The following is a description of a gene set: species: Homo sapiens from publication La Manno G, Gyllborg D, Codeluppi S, Nishimura K, Salto C, Zeisel A, Borm LE, Stott SRW, Toledo EM, Villaescusa JC, Lönnerberg P, Ryge J, Barker RA, Arenas E, Linnarsson S (PMID 27716510) Human Gene Set: MANNO_MIDBRAIN_NEUROTYPES_HRGL3 Cell types are named using anatomical and functional mnemonics prefixed by 'm' or'h' to indicate mouse and human respectively: OMTN, oculomotor and trochlear nucleus; Sert, serotonergic; NbM, medial neuroblast; NbDA, neuroblast dopaminergic; DA0-2, dopaminergic neurons; RN, red nucleus; Gaba1-2, GABAergic neurons; mNbL1-2, lateral neuroblasts; NbML1-5, mediolateral neuroblasts; NProg, neuronal progenitor; Prog, progenitor medial floorplate (FPM), lateral floorplate (FPL), midline (M), basal plate (BP); Rgl1-3, radial glia-like cells; Mgl, microglia; Endo, endothelial cells; Peric, pericytes; Epend, ependymal; OPC, oligodendrocyte precursor cells., and this is the list of marker genes: FLJ16779, KCNMA1, CRB1, TIMP4, MRPL57, FADS2, LRRC17, SIPA1L2, QKI, RHOJ, CMTM4, PAM, ADGRV1, SPON1, CFAP44, SUSD5, TPPP3, PPP1R14C, MAP3K5, ZNF474, SULF2, PSAT1, COBL, MTTP, DNAH6, CPNE8, THSD7A, C6orf89, PLEKHH2, FREM2, EFCC1, TNIK, IFT88, NES, PDE1C, SULF1, PLEKHA5, FAT1, CRISPLD1, DENND2B, SLIT1, HBG2, UCP2, VWA3A, DLG5-AS1, GRIN2A, SCD, SERTM1, ZMAT4, RSPH9, SCN1A, GCA, DTNA, ID4, ITGA6, DCDC2, RNF13, EPCIP, SALL1, HBA2, C6orf118, SPAG1, CELSR1, SLIT2, LRP2BP, KLHL32, IGFBP2, PRLHR, NSMF, ITGB5, MMRN1, DIPK2A, MORN5 (NCBI Gene Id 254956), ZFP36L1, MXRA8, LGI3, ALDH6A1, WNT5A, CPQ (NCBI Gene Id 51670), PLCXD3, KCNIP1, PHGDH, TNFRSF1A, EFHC2, CNPY4, PLTP, GRIA1, DAPK1, EID2B, VAMP5, INHBB, WWC1, PXDC1, NOTCH2, ARHGAP5, ECHDC2, CSGALNACT1, AHNAK, SHROOM3, COL27A1, CDR1, LIFR, CNMD, SMYD3, GPRC5C, ARHGEF28, PDGFC, ALDH9A1, ITM2C, ATP1A2, C2orf72, NRP1, EPHA1-AS1, ADAM9, ITPKB, STEAP3, RFX4, VEPH1 (NCBI Gene Id 79674), YAP1, RWDD3, DSC2, LIPA, NKAIN4, FGF1, TTC29, ALCAM, FJX1, FBXL7, AGBL2, SERPINB6, TFF3, BMP1, RIDA, NADK2, ACSS1, TMC5, CFAP126, CALU, MORN2, LMBRD1, APLP2, GJA1 (gap junction protein alpha 1), TMBIM6, CDH13, KCNN3 (potassium calcium-activated channel subfamily N member 3), DIRAS2 (DIRAS family GTPase 2), NR4A3, CIMAP3, LRP2, PACRG, COL18A1, PTPMT1, AGA, PROM1, RFTN2, GPM6B, AGT, RAB9A, ARHGEF26, TSPOAP1, ROPN1L, PDLIM5, PYCR2, EGR1, SLC1A3 (NCBI Gene Id 6507), FGFR3, EFEMP1, COL8A1, PPP1R3C, EDNRB (endothelin receptor type B), TPP1, ANXA6, ENPP2, PON2, TSC22D4, KIF9, KLF9, SCGB1A1, TRIL, FAT3, RPGR, IQGAP2, CCDC8, DTHD1, ADAMTSL4-AS1, CRIP1, NECTIN3, FAT2, DTX4, HAS2, ITPRID2, CCDC146, ITGB8, CFAP144, H2AC6, OBSL1, CSPG5, HEPACAM, GLB1, TRIM9, CRIM1, PARD3B, DNAJB13, LPAR4, CMTM8 (CKLF like MARVEL transmembrane domain containing 8), ZNF395, PLIN3, CLXN, GALNT3, MPDZ, PLPPR1, AFF2 (ALF transcription elongation factor 2), RAI14, ZBBX, PAPLN, LRRN2 (leucine rich repeat neuronal 2), C12orf76, KCNG1, BCHE, CTNNA3, EGLN3, TMEM18, DNAI4, TIMP3, RXRG, NTN1, HBA1, DDAH1, IFI27L2, KCNAB1, PRCP, MT3, CTSC, TMEM47 (NCBI Gene Id 83604), OSBPL6, NRCAM, ODAD1, ANXA1, IGFBP7-AS1, C1orf226, MBP, CREB5, ETFRF1, LDLRAD4, CDK2AP1, PDPN, TMEM9B, ANXA2, RSPO3, DNAAF3, IL33, FOS, TMEM59L, HYDIN, ABCA8, NDFIP1, MLF1, PBXIP1, SFRP2, ITIH5, ADCY2, ADGRB2, CFAP107, TOM1L2, DNAJB4, LZTFL1, SLC6A9, ZFP36L2, COL6A1, LRIG1, HS3ST1, RERGL, HNRNPCL3, FAH, GALC, FZD3, MEST, TRABD2B, TTR, NDRG4 (NCBI Gene Id 65009), FNDC3B, HDAC4, MAGT1, ANXA5, MAGI2, SPEF1, SPARC, HSPB1, RERG, RANBP3L, IQCG, C12orf75, ARX, HK2, SORCS2 (sortilin related VPS10 domain containing receptor 2), MIR198, KCNE5, TGFB1, PDE3A, CPXM2, COL4A5, LRP1, CCN2, CLU, CACNG4, ADCYAP1R1, CD44, HES4, ARHGEF26-AS1 (ARHGEF26 antisense RNA 1), B4GALT6, F5, HS3ST4, NEBL, ARHGAP24, MUC19, ITSN1, C8orf34, ANKRD9, NR3C1, ERF, HEY1, SNTG1, SOX9-AS1, GNG12 (G protein subunit gamma 12), DSG2, LIPG, IFI35, LYPLAL1, SPARCL1, STAT3, NEK11, DCN, ARMC3 (armadillo repeat containing 3), SORCS1, PMM1, MKX, TAGLN2, DNAH7, FSTL1, FZD1, TPPP, LITAF, CD47, CNTN4, STK33, TRAM2, KCNMB1, VIM, TF, ZNF529-AS1, ZSCAN1, CAST, PPIL6, SPMIP6, TBC1D4, P4HA1, CORIN, TMEM232, OPN5, SRGAP3, EEPD1, ARL6IP5, KCNK2, GLIS3 (GLIS family zinc finger 3), CFAP77, HEPN1, HAPLN1, NXPH1, PDE8B, WWTR1, CD36, RGMA, MIR3652, CFAP45, WFS1, KIRREL3, MAOA, TIMP2, PYGL, FOXA1, DPP6, LGALS3BP, NDNF, CFAP210, HBG1, RSPH1, ID3, CFAP90, MRC2, PREX1, MEMO1, LRRIQ1, MAP7, MNS1, CCN1, SPAG17, CFAP299, LIX1L, CDH4 (cadherin 4), COLEC12, SHISA6, SLC4A4, MAN2A2, FOXJ1, SSPOP, WLS, ENSG00000286190 (NCBI Gene Id 728392), FMNL2, SLC35G2, GATM, SDC2, DHRS3, FOXP2, KLF15, LANCL2, CCDC39, KIFC2, WNT7A, LRRN3, CADM3, IGFBP5, LCA5, TMEM132C, NTRK2, BOC, SLC6A1, STON1-GTF2A1L, FBLN5, CFAP47, DNAAF4-CCPG1, IFT57, KCNMB4, TTYH1, LIX1, DKK3, SOX9, FLNC, GASK1B, SAXO4, CHST6, NME5, SLC44A1, ANTXR1, MAMDC2, FIBIN, DSC3, CETN2, IQCA1, EVI5, LRP1B, RMST, FLRT3, TCIM, NACC2, PLPP3, CIMAP1B, ANO2, MFRP, ATOSA, HTRA1, CFAP276, EFNB3, PDLIM3, RHBDD2, CCDC17, TMEM231, ENKUR, GET1, MGST1, NRBP2, LIMCH1, ARAP2, SMAD9, SOX2, VCAM1, JUN, GAREM2, GNA12, LAMP1, SPOCK1, TXLNB, SALL2, PSAP, SLC7A11, ATF3, CRYAB, TNFRSF11B, GPC4, EVA1C, KLHDC8B, BCAN, AQP4, EPB41L3, CPEB2, ATXN1, ATP1B2 (ATPase Na+/K+ transporting subunit beta 2), VSTM2L, RALGPS2, SLC15A2, THSD4, DNALI1, LRRK2, DYNLT5, CRYZ, CERKL, B3GNT2 (UDP-GlcNAc:betaGal beta-1,3-N-acetylglucosaminyltransferase 2), ACVR1, CHST3, TEKT1, PEA15, NPC2, SPAG16, CATIP (ciliogenesis associated TTC17 interacting protein), RSPH4A, STON1, DAG1, GPR155, RGS6, IRS1, YBX3, SIRT2, PPT1, KCTD12, LAMB2, CHPF, TMEM63A, BCO2, HES5, GDPD2, TACR1, APPL2, HOATZ, SPAG6, DCDC1, MTSS2, CFAP52, P3H4, DLGAP1-AS1, HES1, TSHZ2, JAM2, DCLK1, CDO1, BNC2, TSTD1, PLOD2, PLD3, PMP22, EPHA3, DPP7, NMNAT2, EZR, METRN, EFCAB14 (NCBI Gene Id 9813), HEATR5A, LMCD1, STAT6, CEP126, CRB2, KIF5C, ATP2B2, THUMPD2, GALNT15, DST, PCDHGB4, SLC38A1, HSDL2, CD19, UBL3, EFEMP2, MLC1, CFC1, TBC1D2B, LPL